The following is a description of a gene set: Mouse Gene Set: GOBP_REGULATION_OF_GLUCAGON_SECRETION Any process that modulates the frequency, rate or extent of the regulated release of glucagon. species: Mus musculus, and this is the list of marker genes: Il6, Pask, Irs1, Crh, Ffar4, Nucb2, Cartpt, Aimp1, Lep, Syt7